The following is a description of a gene set: Mouse Gene Set: GOBP_NEGATIVE_REGULATION_OF_AMINE_TRANSPORT species: Mus musculus Any process that stops, prevents, or reduces the frequency, rate or extent of the directed movement of amines into, out of or within a cell, or between cells, by means of some agent such as a transporter or pore., and this is the list of marker genes: Htr1a, Snca, Prkg1 (protein kinase, cGMP-dependent, type I), Crhr2, Il1rn, Rgs2, Agtr2, Gabbr1, Htr1b, Ghsr, Adora1, Htr6, Rgs4, Tnf, Il1b, Abat, P2ry12, P2ry1, Syt4, Slc43a2, Slc15a1, Arl6ip5, Crh, Slc43a1, Hrh3, Crhr1, Grm7, Gck, Chga, Myo5a, Lep, Drd2, Entpd1, Ptgs1, Trh, Cnr1, Npy5r, Ptger3, Syt11